The following is a description of a gene set: Human Gene Set: KEGG_MEDICUS_REFERENCE_ERK_RSK_SIGNALING species: Homo sapiens Pathway Definition from KEGG: ERK -> RSK ERK-RSK signaling. Pathway ID: N01601. Pathway type: Reference. Pathway class: nt06526 MAPK signaling., and this is the list of marker genes: RPS6KA6, MAPK1, RPS6KA3, RPS6KA1, MAPK3, RPS6KA2